Given this list of marker genes PSMD1, ACTR1A, PRPS1, RANGAP1, ENO1, POLA2, EIF3B, CHD4, PCDHB14, TRAP1, here is a description of the gene set: from publication Caffarel MM, Moreno-Bueno G, Cerutti C, Palacios J, Guzman M, Mechta-Grigoriou F, Sanchez C (PMID 18454173) studied in species Homo sapiens It has been recently shown that cannabinoids, the active components of marijuana and their derivatives, inhibit cell cycle progression of human breast cancer cells. Here we studied the mechanism of Delta(9)-tetrahydrocannabinol (THC) antiproliferative action in these cells, and show that it involves the modulation of JunD, a member of the AP-1 transcription factor family. THC activates JunD both by upregulating gene expression and by translocating the protein to the nuclear compartment, and these events are accompanied by a decrease in cell proliferation. Of interest, neither JunD activation nor proliferation inhibition was observed in human non-tumour mammary epithelial cells exposed to THC. We confirmed the importance of JunD in THC action by RNA interference and genetic ablation. Thus, in both JunD-silenced human breast cancer cells and JunD knockout mice-derived immortalized fibroblasts, the antiproliferative effect exerted by THC was significantly diminished. Gene array and siRNA experiments support that the cyclin-dependent kinase inhibitor p27 and the tumour suppressor gene testin are candidate JunD targets in cannabinoid action. In addition, our data suggest that the stress-regulated protein p8 participates in THC antiproliferative action in a JunD-independent manner. In summary, this is the first report showing not only that cannabinoids regulate JunD but, more generally, that JunD activation reduces the proliferation of cancer cells, which points to a new target to inhibit breast cancer progression. Genes down-regulated in EVSA-T cells (breast cancer) treated with 3 micromolar THC (delta-9-tetrahydrocannabinol) for 8 h. Human Gene Set: CAFFAREL_RESPONSE_TO_THC_8HR_3_DN